Given this list of marker genes ADAM28, F2RL2, ZDHHC3, ZNF20, CCDC39, IL1B, GRIK2, DYRK2, KCNH4, HNRNPD, ZBTB10, MYO1F, USP12, ZNF687, CNOT2, SPOUT1, SLC39A8, FEM1C, PGPEP1L, RPS29, SHISA9, BEST3, HSD3B2, BMP2, CNTN5, HTR4, CREB3L1, RNF4, RORA, MAN1C1, PLEKHS1, C1QB, ZNF202, COL11A1, TPD52L3, MEX3C (mex-3 RNA binding family member C), here is a description of the gene set: from publication Chen Y, Wang X (PMID 31504780) studied in species Homo sapiens Genes predicted to be targets of miRBase v22 microRNA hsa-miR-3147 in miRDB v6.0 with MirTarget v4 prediction scores > 80 (high confidence targets). Human Gene Set: MIR3147